Given this list of marker genes Slc25a23, Akt1, Mcur1, Vdac1, Mcu, Psen2, Ucp2, Spg7, Micu3, Smdt1, Opa1, Micu2, Itpr1, Mcub, Maip1, Afg3l2, Hspa9, Micu1, here is a description of the gene set: studied in species Mus musculus A process in which a calcium ion (Ca2+) is transported from the cytosol into the mitochondrial matrix. Mouse Gene Set: GOBP_CALCIUM_IMPORT_INTO_THE_MITOCHONDRION